The following is a description of a gene set: Human Gene Set: GAVISH_3CA_METAPROGRAM_EPITHELIAL_STRESS Genes upregulated in subsets of cells of a given type within various tumors In this study, an extensive analysis was conducted to define meta-programs (MPs) capturing intra-tumor heterogeneity across a spectrum of tumor types. The approach utilized non-negative matrix factorization (NMF) to analyze each cell type separately within individual tumor samples. This involved the analysis of malignant cells, macrophages, fibroblasts, endothelial cells, epithelial cells, T-cells, and B-cells. NMF was executed with varying parameter values (K=4, 5, 6, 7, 8, 9), thereby generating 39 programs for each cell type per sample. Each NMF program was summarized by the top genes based on NMF coefficients.\nRobust MPs were then delineated for each cell type using a set of stringent criteria, including recurrence within the same tumor, similarity to programs in other tumors, and non-redundancy within a tumor. Subsequently, these robust NMF programs were clustered (per cell type) based on Jaccard similarity, leading to the identification of MPs associated with each cell type.\nTo enhance the quality of the MPs, a refinement steps were undertaken, involving the removal of MPs suspected of reflecting low-quality data (with an overrepresentation of ribosomal proteins or mitochondrial-encoded genes), single-study inclusion, or similarity to miss-annotated cell types. studied in species Homo sapiens from publication Gavish A, Tyler M, Greenwald AC, Hoefflin R, Simkin D, Tschernichovsky R, Galili Darnell N, Somech E, Barbolin C, Antman T, Kovarsky D, Barrett T, Gonzalez Castro LN, Halder D, Chanoch-Myers R, Laffy J, Mints M, Wider A, Tal R, Spitzer A, Hara T, Raitses-Gurevich M, Stossel C, Golan T, Tirosh A, Suvà ML, Puram SV, Tirosh I (PMID 37258682), and this is the list of marker genes: JUN, CCN1, SOX4, ELF3, PPP1R15A, CXCL8, ID1, TSC22D1 (NCBI Gene Id 8848), KLF6, GDF15, BCAM, KRT19, KLF4, CXCL2, WSB1, GADD45B, SOCS3, IER2, NFKBIA, NCOA7, RHOB, BTG2, MAFF, ZFP36L1, DNAJB1, CEBPD, FOS, CLDN4 (claudin 4), CLU, CXCL1, EGR1, ERRFI1, NR4A1, IRF1, NEAT1, JUNB, DUSP1, ZFP36L2, JUND, VMP1, IER3, ATF3, MALAT1, KRT17, KRT15, HES1 (NCBI Gene Id 3280), CCNL1, TACSTD2, FOSB, ZFP36